The following is a description of a gene set: Genes down-regulated in mouse embryonic fibroblasts (MEF): untreated versus rosiglitazone. studied in species Homo sapiens Human Gene Set: GSE22033_UNTREATED_VS_ROSIGLITAZONE_TREATED_MEF_DN from publication Choi JH, Banks AS, Estall JL, Kajimura S, Boström P, Laznik D, Ruas JL, Chalmers MJ, Kamenecka TM, Blüher M, Griffin PR, Spiegelman BM (PMID 20651683) In order to identify the molecular mechanisms of PPARgamma phosphorylation at Set273, we generated cell-lines of PPARgamma KO MEFs expressing wtPPARgamma or S273APPARgamma. In addition, because our data showed that PPARgamma ligand drugs such as rosiglitazone and MRL24 blocked this phopshorylation, we treated cells with these drugs, then prepared RNA samples to look at the gene profiling., and this is the list of marker genes: ADIPOR2, EDEM3, FHL2, RRP12, BTG1, ARID5B, NCSTN, OSGIN1, ATXN1, NOL3, SLC12A6, CTSV, RESF1, TSPYL2, PTK2B, CLCN5, ASAP1, ECM2, SULT4A1 (NCBI Gene Id 25830), CRYBB2P1, USP4, BCL2L11 (BCL2 like 11), SH3GLB1, TMEM43, TNIK, MAN1A1, CCND1, REN, LPIN2, NFKB2, DGKB, COQ7, EMP1 (epithelial membrane protein 1), TWF1, DKK2 (dickkopf WNT signaling pathway inhibitor 2), MAPK1IP1L, SDAD1, PLEKHM1, ATG7, CUX1, PANX1, SLC17A9, GOLGA8A, GABRB3 (gamma-aminobutyric acid type A receptor subunit beta3), BCL2A1, CTNNA1, TPBG, TBXAS1, YIPF3 (NCBI Gene Id 25844), CPM, MALT1, CCNA1, STK38L, HGSNAT, MAP4K3, TFE3, SLC23A2, BIRC3, MCOLN1, PER2, HILPDA, ELOVL4, CES2, WDR19 (NCBI Gene Id 80203), IRX4, MIR622, ELMO3, HMG20B, ANKS1B, AVIL, CASP5, GPR22, TNNC2, SEMA6A, MAT2A, TARP, STAT2, GIPR, SAR1A, MYC, GABRA3, MERTK, AP1G2, STX18, FAM13B, SLC25A32, RAB23, RFTN1, DHRS9, IFI44, SELENOT, DDT, GALNT1, CWF19L1, CLDN14, CRNKL1, ZNF274, OTUB1, PITPNA, MMRN2, ZNF292, ABCC10 (NCBI Gene Id 89845), PMEPA1 (prostate transmembrane protein, androgen induced 1), SEPTIN6, GPR65, ALOX15B, ARHGEF7, IL13RA2, PMM2, KDM6A, ETS2, LINC00623, TMCO1, CLCN3, CBFB, DSTYK, DESI1, SIDT2, SPEN, CDK11A, PIP5K1B, C3, RIGI, TFRC, NXF1 (nuclear RNA export factor 1), PPP4R3A, OSBPL2, PDK3, IFI35, MYO1E, WDR45, ZSWIM8, TFG, FLJ13224, BTBD7, SOS1, MDFI, CAV1, PPP1R13L, MATK, NFKBIA, PRODH2, CD72, CTSF, SCHIP1, SLC16A6, CEACAM1, MFSD6, KCNK5, EGR4, NABP1 (NCBI Gene Id 64859), ATF6, ZBTB10, IL6ST, ERP44, IRF4, PTP4A1, SLC7A10, THADA, LIF (NCBI Gene Id 3976), CTSH, MELTF, TNFAIP3, CALCOCO1 (calcium binding and coiled-coil domain 1), PEAK1, ARAP3, PIK3C2B, NGDN, NR1H2, CHD1, CST7, EOLA2, PLPP2, TRIM49, MDM2, MTCL1, CTC1, RBMS2, DUSP10 (dual specificity phosphatase 10), SCG2, ZNF80, UBE2Z, CRHR1, CRIP2, RBM5, LAX1, IFIT2, CHSY1, SIK3, ZNF23, GPR107, PLD1, CEBPB, GLS, POLR1F, CHGA, ATP13A3, KIF13B, TENT5A